The following is a description of a gene set: Mouse Gene Set: CUI_T_CELL_CD4_TSLP_RESPONSE_UP Cytokines mediate cell-cell communication in the immune system and represent important therapeutic targets. A myriad of studies have highlighted their central role in immune function, yet we lack a global view of the cellular responses of each immune cell type to each cytokine. To address this gap, the authors created the Immune Dictionary, a compendium of single-cell transcriptomic profiles of more than 17 immune cell types in response to each of 86 cytokines (>1,400 cytokine-cell type combinations) in mouse lymph nodes in vivo. A cytokine-centric view of the dictionary revealed that most cytokines induce highly cell-type-specific responses. For example, the inflammatory cytokine interleukin-1β induces distinct gene programmes in almost every cell type. A cell-type-centric view of the dictionary identified more than 66 cytokine-driven cellular polarization states across immune cell types, including previously uncharacterized states such as an interleukin-18-induced polyfunctional natural killer cell state. Genes positively differentially expressed in cell type: CD4+ T cell upon treatment with cytokine: TSLP in mouse lymph nodes in vivo. species: Mus musculus from publication Cui A, Huang T, Li S, Ma A, Pérez JL, Sander C, Keskin DB, Wu CJ, Fraenkel E, Hacohen N (PMID 38057668), and this is the list of marker genes: Phgdh, Pa2g4, Eif2s2, Tnfrsf18, Mbd2, Ran, Ncl, Casp8, Flt3l, Cars1, Bcl2, Rexo2, Arl4c, Nop58, Cct8, Igfbp4, Pim1, Ccnd2, Inpp4b, Mettl1, Srsf2, Ppp1r14b, Sars1, Eif5a, Mthfd2, Socs1, Cct5, Nme1, Eno1, Srm, Sh3bp1 (SH3-domain binding protein 1), Eif4a1, C1qbp, Vim, Mrto4